Given this list of marker genes FAH, ZEB2, POLRMT, NRAS, ABCC6, NDUFAF6, ALK, SLC34A3, GATM, CLCN5, HNF4A, KRAS, CTNS, SLC34A1, FGF23, NAB2, SOX5, DMP1, EHHADH, ENPP1, BRAF, STAT6, RAF1, HRAS, PHEX, here is a description of the gene set: Human Gene Set: HP_HYPOPHOSPHATEMIC_RICKETS Hypophosphatemic rickets studied in species Homo sapiens